Given this list of marker genes CDK2, MAX, E2F2, CUL1 (NCBI Gene Id 8454), CCNE2, E2F1, SKP2, MYC, SKP1, RBX1, CCNE1, CDKN1B, RB1, E2F3, CKS1B, here is a description of the gene set: Pathway Definition from KEGG: (MYC*+MAX) => CKS1B -> (SCF+SKP2) -| CDKN1B -| (CCNE+CDK2) -> RB1 // E2F species: Homo sapiens Amplified MYC to p27-cell cycle G1/S. Pathway ID: N00092. Pathway type: Variant. Pathway class: nt06267 Small cell lung cancer. Human Gene Set: KEGG_MEDICUS_VARIANT_AMPLIFIED_MYC_TO_P27_CELL_CYCLE_G1_S